Given this list of marker genes SLC24A4, UCN, ACE2, REN, DRD2, EN1, TACR1, MMP17, APLN, OXT, TMEM63B, here is a description of the gene set: species: Homo sapiens Human Gene Set: GOBP_DRINKING_BEHAVIOR The specific behavior of an organism relating to the intake of liquids, especially water.